Given this list of marker genes TCF7L2, PAX6, FFAR4, LEP, SPCS1 (NCBI Gene Id 94556), GNB3, FFAR1, CTNNB1, SEC11C, GNB1, GNG13, CDX2, GPR119, DPP4, GNAT3, PCSK1, SPCS2, GRP, GCG, SPCS3, SEC11A, here is a description of the gene set: Reactome Pathway: Synthesis, secretion, and inactivation of Glucagon-like Peptide-1 (GLP-1) part of: Incretin synthesis, secretion, and inactivation species: Homo sapiens In L cells of the intestine the transcription factors TCF-4 (TCF7L2) and Beta-catenin form a heterodimer and bind the G2 enhancer of the Proglucagon gene GCG,activating its transcription to yield Proglucagon mRNA and, following translation, Proglucagon protein. The prohormone convertase PC1 present in the secretory granules of L cells cleaves Proglucagon at two sites to yield mostly Glucagon-like Peptide-1 (7-36) with a small amount of Glucagon-like Peptide-1 (7-37). Glucagon-like Peptide-1 (7-36 and 7-37) (GLP-1) is secreted into the bloodstream in response to glucose, fatty acids, insulin, leptin, gastrin-releasing peptide, cholinergic transmitters, beta-adrenergic transmitters, and peptidergic transmitters. The half-life of GLP-1 in the bloodstream is determined by Dipeptidyl Peptidase IV, which cleaves 2 amino acids at the amino terminus of GLP-1, rendering it biologically inactive.